Given this list of marker genes HERC3, GNE, ZNF169, ZXDC, WIPF2, ACKR2 (atypical chemokine receptor 2), SEC14L1, TRRAP, HNRNPR, ATOX1, NR3C1, CSNK1E, LUC7L2, DOCK8-AS1, RTKN2, PNMA2, FOXJ2, USP37, ZDHHC2 (NCBI Gene Id 51201), RUSC1, APEX2, NIPAL3, ARIH2, LIF, HOOK3, NR4A3, OTUD6A, NACC2, ZNF709, GPATCH8, SPOCK1, AFAP1 (NCBI Gene Id 60312), BCL11B, UBXN1, VPS26B, WDR48, TRAF3IP1, AP1S3 (adaptor related protein complex 1 subunit sigma 3), TPTEP2-CSNK1E, MAP10, SCN2B, GPATCH2L, RAB5A, C5AR1, PRRC2B, RANBP10, MYO5C, E2F7, BLMH, KLHL7, FBXO41, GID4 (GID complex subunit 4 homolog), LENG8, ADIPOQ, MED14, IGDCC4, UBN2, TNR, ANGPT4, NDUFA10, E2F3, ATP6AP1, ABHD2, KIAA1217, PITPNM3, POU2AF1, MLLT11, SRCIN1, FAM168A, ADRB3, CSTF2T, PRLR, PEAK1, PARP11, FNDC5, BMP3, C11orf87, KCNK9, ALS2, RAB6B, TTLL7, ANKRD13C, AAK1, HAND1, FGD6, GUCY1A2, SCOC, SLC7A1, HLTF, DDR1, REEP4, MASP1, FAM222A, EEF1AKMT3, ZNF664, IL18BP, CALCA, TFAP2B, PIP4P1, CDIP1, TTC13, ST6GALNAC5, GRAMD1B, FN3KRP, RPA1, BCAM, PABIR3, MPZL2, JMJD8, TMEM25, SATB2, GJB1, GLRB, GJA4, PGRMC2, SRGAP2, KIAA0825, NALF1, MPRIP (myosin phosphatase Rho interacting protein), RNF157, CCDC149, SCAF11, ALOX15, WDR33, EBF2, ELFN2, DLEU7, SH2B3, SDK1, ANKRD45, TAL1, BHLHE40, CDK6, KRT38, USP12, RAB15, PLSCR1, JCAD, SPMIP5, UNC80 (NCBI Gene Id 84540), LANCL1, JPH1, TAP2, TVP23A, DPYSL2, FCGR1BP, NR6A1, C5orf24, PTAR1, HTR2C, LRIT3, MLH3, SUSD6, PCGF3, NEBL, NABP2, ONECUT2, ZNF585B, XPR1, ZFYVE26, ADGRF2P, RAB11FIP2, PDP2, TMEM138, VCL, SHISA9, DLG2, SOCS7, SHISA6, C6orf136 (NCBI Gene Id 221545), LRRTM4, NFAT5, ELK4, SH3TC2, SSH2, PIP5K1A, KDM5C, POU3F1, C9orf152, PSMD11, CEACAM1, HOXA3 (homeobox A3), ASTN1, MAN2A1, ZC4H2, TWIST1, SRGAP3, TRIM22, HMG20A, WASF2, ACSL4, P2RY10, EHD2, LSAMP, HMGXB4, MSMO1, ZNF609, ACVR2B, INSM2, TOR1AIP1, VAMP2, FSCB, TMED4, TTI2, SOCS4, ATAD2 (ATPase family AAA domain containing 2), MRPS16, PHF8, CAMK2D, SNX27, TSC22D2, PHB1, PHF21A, RAD18, FRZB, AK4, CAMKV, SV2C, MTCL2, FEM1B (NCBI Gene Id 23374), SMARCD1, DCAF7 (DDB1 and CUL4 associated factor 7), CREB3L2, UBQLN2, C9orf57, PARPBP, TRMT10B, OSBP, LCT, EPHA8, here is a description of the gene set: Human Gene Set: MIR6876_5P species: Homo sapiens from publication Chen Y, Wang X (PMID 31504780) Genes predicted to be targets of miRBase v22 microRNA hsa-miR-6876-5p in miRDB v6.0 with MirTarget v4 prediction scores > 80 (high confidence targets).